Given this list of marker genes LDLRAP1, ZFP62, SEC22C, IRAK4, CCNG1, ANKRD13D, BCL9L, ACTR6, RNF39, ABHD15, PUM1, NRP1, TBCK, ZFP36L1, ITPRIP, TBC1D32, TSN, C18orf54, CRYBG3, B3GNT9, TBCEL, GNS, FGF2, ACAP1, TRMT1, RAB11FIP4, TRIM2, TIMELESS, GPD1L, RPS6KA5, ATOSB, CASP9, PTPN12, ADCY7, ACP5, MTURN, TIMMDC1, H3-5, FAM114A1, PSIP1, HVCN1, ANXA7, RINT1, GPR19, TMEM65, APOBEC1, CENPI, SLC25A33, OTUD1, LRRC75B, PMM1, ACSBG1, UBE2D2 (ubiquitin conjugating enzyme E2 D2), SEC23A, S100A5, ARHGAP18, RAB42, NEURL1B, CCDC34, DBT, MAGT1, PCBP4, UBE2O, ARRB2, PRKACB, SMC4, NCOR1, CPLX4 (complexin 4), DTX4, C12orf75, SPATA13, ABCC5, TMEM150C, ARHGAP30, ARL2BP, OVGP1, ITPKC, KDM5B, FCHO2, GATAD2B, ZBTB44, COMT, SIDT2, MTRR, CNN2, TNFRSF12A, SRGAP2, PCMTD1, GPN1, CEP104, GPR85, EMC9, CWC22, GALNT2, LDLRAD4 (NCBI Gene Id 753), DNAJC5G, CARD11, HSPA13, GSS, MCTP2, IRF6, SLC45A3, TRPV2, CRYZL1, RYR3, EXOC6, ACSS2, SNX12 (NCBI Gene Id 29934), ANKMY2, ANKRD49, GRHL1, SLC19A2, TMEM64, CYP1A1, BEND4, MED14, SPMIP8, HEG1, LRFN5, MYB, HIRIP3, KLF7, MYO1F, RPS6KA3, CCDC65, THY1, TRIM67, CDC25B, VAMP2, TAGLN2, ABTB3, CBX7, CDHR1, CERK, CHST15, TP53INP1, RNF24, PIAS3, PGAP1, PURG, ACTL6B, IL1RL2, MARCHF3, KIF21B, DIABLO, PTPN22, STK17B, DMTF1, PTPRK, OSBPL9, ADH1C, TPCN1, TXNRD3, CEP55, GUCD1, PGM2L1, METTL2B, DDX51, STK26, DNAJC10, PABPC1, NDRG2, MNT, PEX26, RECK, SLC35D2, SPCS3 (signal peptidase complex subunit 3), COLGALT1, MSN, PITPNM1, TPR, XPC, INHBC, ZFP36L2, ADD1, ZRANB3, PRXL2C, PPP1R14B, CEP295, PTTG1, IPCEF1 (NCBI Gene Id 26034), TFEC, GMEB2, FNTA, SPN, ITGB5, PPARGC1B, UBE2H (NCBI Gene Id 7328), NUDT16, CEP68, ERAL1 (NCBI Gene Id 26284), ZNF679, MEF2D, SNX30, DPM3, HEXB, XRN2, RINL, S100A11, BRD9, here is a description of the gene set: species: Homo sapiens from publication Ventre E, Brinza L, Schicklin S, Mafille J, Coupet CA, Marçais A, Djebali S, Jubin V, Walzer T, Marvel J (PMID 22942430) Human Gene Set: GSE32423_IL7_VS_IL4_MEMORY_CD8_TCELL_UP Effects of IL-4 on CD8 T cells functions are largely unknown. IL-4 induces survival and proliferation of CD8 T cells, but several studies suggest that IL-4 could also affect several functions of CD8 T cells such as cytotoxicity. Our team has shown that IL-4 repress the expression of Ccl5 in vitro. To define more precisely the impact of IL-4 on CD8 T cells, we performed a whole genome expression microarray analysis of naive and memory CD8 T cells cultured in presence or absence of IL-4. This approach allowed us to define the IL4-gene-expression signature on CD8 T cells. Genes up-regulated in comparison of memory CD8 T cells treated with IL7 versus those treated with IL4.